Given this list of marker genes Tmem68, Cyp26a1, Pcdh20, Nsmce4a, Stxbp3, Ppp4r4, Cnr1, Krit1, Ilrun, Etl4, Olig3, Or51e1, Azin1 (antizyme inhibitor 1), Pkp1, Zfp281, Magi2, Eny2, Anp32e, Slc10a7, Ssr3 (signal sequence receptor, gamma), Bmp5, Styx, Tceal7, Pitpnc1, Stab2, Cyp3a25, Erh, Mmp19, Kcne3, Pigg, Kcnma1, Lhx9, Immp1l, Ntf3, Stox2, Cyp3a59, Pum2, Gpm6a, Tut7, Tmem178b, Aplp2, Tmem196, Bod1l, Sp3, Dyrk1a (NCBI Gene Id 76465), Zfp367, Pde10a, Tmem204, Vti1b, Mier3, Calcoco1, Asap2, Nme7, Rnf38, Cpxcr1, Snrnp40, Fosl2, Snx6, Homer1, Rp2, Tead1, Trib2, Cycs, Cdh8, Zeb2, Slc39a6, Gimap8, Sema3c, Adam2, Sirt1, Pde4d (phosphodiesterase 4D, cAMP specific), Atp2a2, Fancd2os (Fancd2 opposite strand), Nlk, Reps2, Atf2, here is a description of the gene set: Mouse Gene Set: MIR_154_3P species: Mus musculus Genes predicted to be targets of miRBase v22 microRNA mmu_miR_154_3p in miRDB v6.0 with MirTarget v4 prediction scores > 80 (high confidence targets). from publication Chen Y, Wang X (PMID 31504780)